Given this list of marker genes SOX9, SHH, GDF5, TBX1, PAX2, HIF1A, PAX8, HNF1B, BMP7, POU3F4, here is a description of the gene set: species: Homo sapiens Human Gene Set: GOBP_NEGATIVE_REGULATION_OF_MESENCHYMAL_CELL_APOPTOTIC_PROCESS Any process that stops, prevents or reduces the frequency, rate or extent of mesenchymal cell apoptotic process.